The following is a description of a gene set: Any process that activates or increases the frequency, rate or extent of cellular senescence. Mouse Gene Set: GOBP_POSITIVE_REGULATION_OF_CELLULAR_SENESCENCE species: Mus musculus, and this is the list of marker genes: Pawr, H2-M3, Eef1e1, Cgas, Sirt1, Trp53, Ypel3 (NCBI Gene Id 68930), Mtor, Kras, Ilk, Arg2, Abi3, Morc3, B2m